Given this list of marker genes ZMYND12, NAA15, RPS6KA3, FIGN, SYNE3, UBR5, MAN2A1, FBXO38, PPM1E, ANKRD54, DUS1L, SYTL5, ZNF436, PGM2L1, GXYLT2, ARCN1, GADL1, DNAJC15 (NCBI Gene Id 29103), SPIN4, FSTL5, TFAP2A, BORA, OIT3, TXNDC11, RELL1, FARP1, TAOK1 (NCBI Gene Id 80214), LRP2, OR51E2, TNPO1, WIF1, GCNT2, LIN28B, DENND4A, SUZ12, AMOT, NCOA7, PRKCH, LPIN3, EPHA7, MTMR7, CDKL2, TMEM47, ZNF629, BRWD1, LRTOMT, CHCHD3, FRS2, SLC35E4, SUMF1, PLEKHA8, MEIS1, SH3PXD2A, ZNF800, MEX3D, SEC22B, SEMA5A, SLC16A6, CCSAP, ZNF281, MMP24, HOOK3, BICC1, MYH15, GPATCH11, FKBP5, ANO1, DMTF1, PIK3CB, MEAK7, BCL10, PKHD1L1, TUT4 (NCBI Gene Id 23318), KLHL24, RHOT1, GLIS3, here is a description of the gene set: species: Homo sapiens Human Gene Set: MIR3938 from publication Chen Y, Wang X (PMID 31504780) Genes predicted to be targets of miRBase v22 microRNA hsa-miR-3938 in miRDB v6.0 with MirTarget v4 prediction scores > 80 (high confidence targets).